The following is a description of a gene set: studied in species Mus musculus Mouse Gene Set: GOBP_POSITIVE_REGULATION_OF_MYELINATION Any process that activates or increases the frequency, rate or extent of the formation of a myelin sheath around nerve axons., and this is the list of marker genes: Sgms1os1, Ngfr, Itgax, Srebf2, Dicer1 (NCBI Gene Id 68462), Mir23a, S100b, Ncmap, Dag1, Trf, Pard3, Tenm4, Wasf3, Nrdc, Cst7, Cdk18, Mag, Sox10, Myrf, Rnf10, Igf1, Tppp, Hgf, Egr2, Tnfrsf1b, Qki, Zfp488 (zinc finger protein 488), Hnrnpk (NCBI Gene Id 15387), Slc25a12